The following is a description of a gene set: studied in species Homo sapiens from publication Chen Y, Wang X (PMID 31504780) Genes predicted to be targets of miRBase v22 microRNA hsa-miR-3672 in miRDB v6.0 with MirTarget v4 prediction scores > 80 (high confidence targets). Human Gene Set: MIR3672, and this is the list of marker genes: KAT6A, USP22, BMPR2, MTARC1, POT1, ANTXR1, USP15, EIF4A2, SV2B, EPB41L4A, ZBTB41, ZNF662, MAPK3, CDK2AP1, GPATCH2, PUM1, ABCB10, MAP1A, HRH4, RSPRY1, FAM107B, BZW1, RFLNB, CHRNA9, KMT2C, ZNF443, STK39, GASK1B, RBM8A, VSNL1, MTCH2, CCT6B, RSKR, HDAC9, FXR1, FRMPD4, RPL13, ZNF331, CHL1, ETV5, ARHGAP29, EMP2 (epithelial membrane protein 2), KHDRBS2, RIMBP3B, PLA2R1, CALCRL, KIRREL1, CNTN1, MRPS18B